Given this list of marker genes GNAO1, CALM1, ADGRV1, GRM7, CALM3, GNAI1, RGS2, GNAZ, RAF1, GNAL, CALM2, GNAS, here is a description of the gene set: Human Gene Set: GOMF_ADENYLATE_CYCLASE_REGULATOR_ACTIVITY Binds to and modulates the activity of adenylate cyclase. species: Homo sapiens